Given this list of marker genes EDNRB, PAPSS2, ACTR6 (actin related protein 6), SAC3D1, MPHOSPH9, SLC1A4, WT1-AS, SGCB (sarcoglycan beta), ALDOA, HES1, DLK1, MYBL1, SEC61G, MEG3, SPIDR, ENPP2, MEAK7, EMX2, ATP9A, ZNF423, NCOA1, P2RY1, here is a description of the gene set: from publication Buckanovich RJ, Facciabene A, Kim S, Benencia F, Sasaroli D, Balint K, Katsaros D, O'Brien-Jenkins A, Gimotty PA, Coukos G (PMID 18157142) Genes down-regulated in microdissected endothelial samples from ovarian cancer tumors with tumor-infiltrating lymphocytes (TIL) vs those without TILs. In spite of their having sufficient immunogenicity, tumor vaccines remain largely ineffective. The mechanisms underlying this lack of efficacy are still unclear. Here we report a previously undescribed mechanism by which the tumor endothelium prevents T cell homing and hinders tumor immunotherapy. Transcriptional profiling of microdissected tumor endothelial cells from human ovarian cancers revealed genes associated with the absence or presence of tumor-infiltrating lymphocytes (TILs). Overexpression of the endothelin B receptor (ET(B)R) was associated with the absence of TILs and short patient survival time. The ET(B)R inhibitor BQ-788 increased T cell adhesion to human endothelium in vitro, an effect countered by intercellular adhesion molecule-1 (ICAM-1) blockade or treatment with NO donors. In mice, ET(B)R neutralization by BQ-788 increased T cell homing to tumors; this homing required ICAM-1 and enabled tumor response to otherwise ineffective immunotherapy in vivo without changes in systemic antitumor immune response. These findings highlight a molecular mechanism with the potential to be pharmacologically manipulated to enhance the efficacy of tumor immunotherapy in humans. Human Gene Set: BUCKANOVICH_T_LYMPHOCYTE_HOMING_ON_TUMOR_DN species: Homo sapiens